Given this list of marker genes Cyfip1, Flnb, Strip2, Nfil3, Creb5, Ktn1, Cyth3, Etv6, Anxa2, Serpina3g, Ly75 (NCBI Gene Id 17076), Vdr, Ggta1 (glycoprotein galactosyltransferase alpha 1, 3), Gbp5, Bcl2a1a, Sik3, Gsap, Fgl2, Sema7a, Fchsd2, Ehd1, St8sia4, Mt2, Acsl5, Ptpn1, Calm1, Lactb, Slfn2, Cytip, Gpd2, Orai1, Selplg, Trim25, Il1rn, Actr3 (ARP3 actin-related protein 3), Ncoa7, Cish, Vim, Mkrn1, Cd302, Abtb2 (NCBI Gene Id 99382), Gcnt2, Rnf19b, Socs1, Noct, Ptger4, Coro1c, Pdlim5 (NCBI Gene Id 99766), Klf6, Ntmt1, Scn3a, Cfl1, Socs3, Il10ra, Cd86, Glipr2, Mir155hg, Nuak2, Crem, Xbp1, P2ry10, Serpinb9, Erh, Cacna1d, Irf5, Gbp7, Dock10, Zfp942, Gpbp1, Rap2a, Atp6v0a1, Cd63, Nrp2, Nckap1l, Ramp3, Chd7, Gtpbp4, Id2, Pik3r1, Mmp25, Adgrg6, Bcl2a1b, Jaml, Wipf1, Fscn1, Ccl22, Slc27a3, Runx3, Ifitm2, Cdkn1a, Ctsz, Ccr7, Actg1, Actn1, P2rx4, Mylk, Ikzf4, Suv39h2, Trim35, Sphk1, Cd83, Mfhas1, Rgs1, Plk2, Lcp1, Itga4 (NCBI Gene Id 16401), Ikbkb, Prdm1, Cyrib, Yes1, Pcyt1a, Pde4b, Tcaf2, Nectin2, Picalm, Bcl2l11, Ocln, Ier3, Txn1, Cst3, Cd80, Pdcd1lg2, Mbp, Ndrg1, Adra1a, Syngr2, Il1b, Marcks, Srgn, Tagln2, Plekha1, Bach1, Nr4a3, S100a11, Etnk1, Gpr141, Ikzf1, Adprh, Cd274, Clic4, Pim1, Jak2, Stxbp6, Tmem131l, Coro2a, Myh9, Csrp1, Serpinb6b, Hcls1, Bcl2a1d, Cxcl9, Wnk1, Plek2, Pkib, Tle3, Ralb, Riok3, Nae1, Ahnak, Scimp, Tes, Prps1, Ccl17, Large1, Got1, Ssh1, Vwa5a, Rel, Rab8b, Nmb, Sft2d2, Pik3r5, Jdp2, here is a description of the gene set: Mouse Gene Set: CUI_LANGERHANS_IL1A_RESPONSE_UP Cytokines mediate cell-cell communication in the immune system and represent important therapeutic targets. A myriad of studies have highlighted their central role in immune function, yet we lack a global view of the cellular responses of each immune cell type to each cytokine. To address this gap, the authors created the Immune Dictionary, a compendium of single-cell transcriptomic profiles of more than 17 immune cell types in response to each of 86 cytokines (>1,400 cytokine-cell type combinations) in mouse lymph nodes in vivo. A cytokine-centric view of the dictionary revealed that most cytokines induce highly cell-type-specific responses. For example, the inflammatory cytokine interleukin-1β induces distinct gene programmes in almost every cell type. A cell-type-centric view of the dictionary identified more than 66 cytokine-driven cellular polarization states across immune cell types, including previously uncharacterized states such as an interleukin-18-induced polyfunctional natural killer cell state. from publication Cui A, Huang T, Li S, Ma A, Pérez JL, Sander C, Keskin DB, Wu CJ, Fraenkel E, Hacohen N (PMID 38057668) species: Mus musculus Genes positively differentially expressed in cell type: Langerhans upon treatment with cytokine: IL-1α in mouse lymph nodes in vivo.